The following is a description of a gene set: Human Gene Set: GOBP_REGULATION_OF_MICROVILLUS_ORGANIZATION species: Homo sapiens Any process that modulates the frequency, rate or extent of a process involved in the formation, arrangement of constituent parts, or disassembly of a microvillus., and this is the list of marker genes: CDHR2, PLS1, KLF5, USH1C, FSCN1, PLD1 (phospholipase D1), CDHR5, RAP1GAP, VIL1, ATP8B1, EZR, PODXL, TWF2